The following is a description of a gene set: Reactome Pathway: NPAS4 regulates expression of target genes This event has been computationally inferred from an event that has been demonstrated in another species.<p>The inference is based on the homology mapping from PANTHER. Briefly, reactions for which all involved PhysicalEntities (in input, output and catalyst) have a mapped orthologue/paralogue (for complexes at least 75% of components must have a mapping) are inferred to the other species. part of: Transcriptional Regulation by NPAS4 studied in species Mus musculus electronically inferred by orthology from the curated human pathway, and this is the list of marker genes: Bmal1, Npas4, Maged1, Arnt2